Given this list of marker genes Pmch (NCBI Gene Id 77764), Ahcyl, Ptger3 (prostaglandin E receptor 3 (subtype EP3)), Kcna2, Parp1 (NCBI Gene Id 98479), Hcrtr2, Bloc1s6, Alb, Pln, Uts2, Ghrhr, Gabrb3, Nr1d1, Npas2, Npy2r, Chrnb2, Ghrh, Casp1 (NCBI Gene Id 12362), Nlgn1, Ptger4, Adora1, Nlgn3, Adrb1, Nmu, Drd2 (dopamine receptor D2), Btbd9, Ptgds, Ahcy, Nps, Csf2, Uts2r, Adora2a, Ada, Th, Il6, Per3, Drd3, Mtnr1b, Ghrl, Fxr1, Drd1, Cntnap2, Cort, here is a description of the gene set: studied in species Mus musculus The cycle from wakefulness through an orderly succession of sleep states and stages that occurs on an approximately 24 hour rhythm. Mouse Gene Set: GOBP_CIRCADIAN_SLEEP_WAKE_CYCLE